The following is a description of a gene set: species: Homo sapiens The cellular developmental process by which a cell establishes the intrinsic character of a cell or tissue region irreversibly committing it to a particular fate. Human Gene Set: GOBP_CELL_FATE_COMMITMENT, and this is the list of marker genes: CYLD, HOXA2, GATA4, WT1, BMP2, GATAD2B, MGA (NCBI Gene Id 84130), NEUROG1, BRD2, WNT7B, TP53, ASCL1, BRD4, LGALS1, TNFSF18, WNT9B, GDF7, HDAC2, TBX10, HES1, TNXB, HEY2, MYF5, WNT10A, GATA2, HOXA13, RUNX2, EDNRA, NEUROD4, DLL4, NRP1, MIR1-1, TBX3, PTF1A, LEO1, TBX1, NOTCH2, TGFBR1, OLIG1, VSX2, SOX9, ZFPM1, IL12RB1, MITF, FKBP8, LATS2, GATA6 (GATA binding protein 6), FOXA2, JAK3, NOTCH1, LATS1, NKX2-1, ONECUT2, NOTCH3, TCF7L2, BCL2, SPRY2, LBX1, FOXN4, BRAF, SIX2, TBX19, WNT2B, TLX3, SIX1 (NCBI Gene Id 6495), MNX1, MTOR, RTF1, EOMES, ID2 (inhibitor of DNA binding 2), TBXT, PRKDC, FOXI3, ZDHHC16, NKX2-2, WNT2, SOX2, ATOH1, STAT3, ELF5, PRDM11, FGFR1, FZD7, IL6, ETS2, TBX6, GLI3, CASP3, PAX6, WNT8A, MTA3, SUFU, MIR208A, POU3F2, BATF, OLIG2, FOXC2, TAL1, GSX1, WNT9A, RAG2, ISL1, PDPN, TBR1, FOXN1, NODAL, PSEN1, ESRP1, EYA2, SHH, MYOD1, KDR, WNT8B, WNT7A, PAX2, WNT4, RBPJ, MIR19B1, DLL1, CTR9, DLX1, GAS1, TM2D3, PML, DMRTA2, FGF10, IHH, NKX2-5, NTRK3, HOXC10, STAT6, GATA1, MTA1, MTA2, SMAD4, CTNNB1, DLX2, BARHL2, LOXL3 (NCBI Gene Id 84695), MIR133A1, GATA3, PRDM1, TBX18, JAK1, TBX20, RBBP7, SOX18, SOCS3, BMPR1A, NANOG, MIR206, SPN, APC2, GBX1, EYA1, HNF1B, LY9, EXT1, CYP26B1, CDC42, CD69, PAX7, CHD3, FGF2 (NCBI Gene Id 2247), DOCK7, GLI2, RBBP4, PTCH1, NKX2-3, TBX21, OPA1, CHD4, PPARG, WNT3, PROX1, PRRX1, TBX5, FOXP3, DBX1 (NCBI Gene Id 120237), RAB10, APC, TGFB2, DHH, NOTCH4, EDN1, TBX4, SMAD1, FGF13, EP300, NFIA, MBD3, TEAD3, TBX15, ARHGEF2, HES5, SOX8, IRF4, SMAD2, CTSL, HOXA11, WNT3A, HOXD10, GDF3 (growth differentiation factor 3), PRDM14, NR2E1, ITGB1, IL23R (interleukin 23 receptor), TBX22, SMO, IL6R, NR2F2, KDM6B, CDC73, IL12B, SOSTDC1 (sclerostin domain containing 1, NCBI Gene Id 25928), GSC, MIR125A, GSX2, SFRP2, OLIG3, MYT1L, FEV, EPOP, NKX6-2, GCM1, MYOG, SLAMF6, BCL11B, TFAP2C, TRIM15, SOX17 (NCBI Gene Id 64321), LHX3, SOX5 (NCBI Gene Id 6660), DSCAML1, MCL1, MYL2, EPAS1, SOX13, GATAD2A, JAG2, FOXG1, FGFR2, LMO4, TEAD4, PAF1, FEZF2, SMAD5, NEUROD1, EBF2, DKK1, SPDEF, WNT10B, SOX6, FGF8, WNT11, GAP43, FOXA1, TCF3, IFRD1, POU4F1, TGFB1I1, SFRP1, WNT16, BMP4, NFE2L1, PITX1, ERBB4, MEF2C, DMRT3 (NCBI Gene Id 63949), TBX2, WNT5A (NCBI Gene Id 7474), ATOH7, SLAMF8, MYF6 (NCBI Gene Id 4618), JAG1, ACVR1, STAT5A, ISL2, IL7, TOX, PTCH2, IL23A, RHOA, ARX, ZNF521, WNT6, KLF4, SOX1, POU5F1, NFIB, IL6ST, TENM4, NKX6-3, HDAC1, MESP1, RARA, ONECUT1, WNT5B, GATA5, WNT1, EHMT2, CDON